The following is a description of a gene set: from publication Chen Y, Wang X (PMID 31504780) Genes predicted to be targets of miRBase v22 microRNA hsa-miR-95-3p in miRDB v6.0 with MirTarget v4 prediction scores > 80 (high confidence targets). species: Homo sapiens Human Gene Set: MIR95_3P, and this is the list of marker genes: RAI14, EOLA1, PURG, MROH2A, IL1RAP (NCBI Gene Id 3556), UBE4B